The following is a description of a gene set: species: Mus musculus Any process that activates or increases the frequency, rate or extent of proteasomal protein catabolic process. Mouse Gene Set: GOBP_POSITIVE_REGULATION_OF_PROTEASOMAL_PROTEIN_CATABOLIC_PROCESS, and this is the list of marker genes: Usp13, Lrrk2, Csnk1e, Bag6, Fbxw8, Vcp, Cbfa2t3, Gsk3a, Kcne2, Sh3rf2, Trib1, Trib2, Bag2, Hspa1b, Dab2, Csnk1d, Nub1, Sh3rf3, Fbxo22, Rnf180, Il33, Ube2v2, Trf, Fzr1, Eif2a, Zfand2a, Wfs1 (wolframin ER transmembrane glycoprotein), Rbx1, Fbxw7, Cdc20, E330034G19Rik, Rnf40, Fmr1, Stub1, Tmem259, Csnk1a1, Cdc20b, Axin1, Akt1 (thymoma viral proto-oncogene 1), Nupr1, Prkn (parkin RBR E3 ubiquitin protein ligase), Gabarap, Cop1, Plk1, Usp5, Zyg11b, Gclc, Nkd2, Ern1, Pias1, Hspbp1 (NCBI Gene Id 66245), Klhl40, Sirt1, Axin2, Ubqln2, Prickle1, Socs5, Dnajb2, Ddrgk1, Osbpl7, Eif2ak3, Sh3rf1, Rnft1, Sumo2, Atxn3, Zer1, Psen2, Mdm2, Mapk9 (NCBI Gene Id 26420), Mapk8 (mitogen-activated protein kinase 8), Sumo1, Chfr, Tmx1, Nop53, Rchy1, Herpud1, Oaz1, Clu, Psen1, Dda1, Tmtc3, Psmd10, Hamp, Ecscr, Rbx1-ps, Det1, Rnf185, Sirt6 (NCBI Gene Id 72769), Socs4 (suppressor of cytokine signaling 4), Atg7, Bbs7, Sirt2, Aurka (aurora kinase A), Bcap31, Dab2ip, Cav1, Paqr3, Trem2, Gba1, Rad23a, Rack1 (receptor for activated C kinase 1), Hspa1a, Trib3, Plk3, Tmem67, Xbp1, Plk2, Pabir1, Dvl1, Ubqln1, Rnft2, Sgta, Gsk3b